Given this list of marker genes PPP1R12A, IKBKB, F2RL1, PLCB1, RAPGEF1, ZDHHC21, CLDN3, RAPGEF6, PROC, MSN, CDH5, ICAM1, CLDN5, RDX, EDNRB, ROCK2, S1PR3, EZR (ezrin), MARVELD2, TNF, TJP1, ROCK1, TJP2, CLDN1, AFDN, RAB1B, EDNRA, S1PR2, RAP1A, TNFRSF1A, FOXP3, RAP2B, PTPRS, RAP2C, RAP1B, PPP1R16B, RAPGEF2, VCL, HPSE, MYD88, TJP3, ROBO4, PDE4D, PDE2A, F11R, RAB1A, ADD1, PECAM1, FASN (fatty acid synthase), MYADM, VEGFA, RAPGEF3, IL1B, SOX18, here is a description of the gene set: studied in species Homo sapiens The establishment of a barrier between endothelial cell layers, such as those in the brain, lung or intestine, to exert specific and selective control over the passage of water and solutes, thus allowing formation and maintenance of compartments that differ in fluid and solute composition. Human Gene Set: GOBP_ESTABLISHMENT_OF_ENDOTHELIAL_BARRIER